The following is a description of a gene set: species: Homo sapiens Human Gene Set: GOBP_MONOATOMIC_ANION_HOMEOSTASIS Any process involved in the maintenance of an internal steady state of monoatomic anions within an organism or cell. Monatomic anions (also called simple anions) are anions consisting of exactly one atom., and this is the list of marker genes: FASLG, KCNE3, SLC12A9, SLC12A4 (NCBI Gene Id 6560), CA12, SLC12A1, KCNQ1, SLC12A2, SLC12A5 (NCBI Gene Id 57468), UMOD, SLC12A3, WNK4, WNK1, SLC12A7, CPS1, TBXAS1, STK39, ATP6V1B1, SLC12A8, OTC, SLC12A6